Given this list of marker genes VTA1, BCR, SPRTN, SSX5, BCAM, ZFAND4, MTFR1, MPC1, ING5, UFSP1, CBLN4, MRPL41, RAB39B, PTRH2, STYK1, DCK (NCBI Gene Id 1633), C16orf90, ZCCHC17, GART, MAF1, PLPP4, POU5F2, TUBGCP6 (NCBI Gene Id 85378), SLPI (secretory leukocyte peptidase inhibitor), C1orf159, PLEKHN1, USP24, FMR1, SLC16A6, GTF3C6, SMTN, TBC1D9B, DHRS1, D2HGDH, AKNA, VAV1, OR2T33, SRSF1, SLC29A2, LRRC46, ACAP2, DCLRE1B, ATP10A, ZCCHC14, MEMO1, TM9SF3, RNGTT, SETDB1, NADK, P2RX1, NEUROD2, IPPK, PITPNB, HMGXB4 (NCBI Gene Id 96789), INSR, FKRP, ARHGEF1, HYAL3, MSL3, BBOX1, SMIM7, CHD1L, ARSB, USP37, SSX2IP, MTF1, RIF1, ACSL5, MKLN1, MOB3A, CNGA4, PACC1, MAB21L2 (NCBI Gene Id 10586), NOCT, OOEP, KLHL36 (NCBI Gene Id 79786), MIB2, GALC, RUFY1 (NCBI Gene Id 80230), FAM216A, MAS1 (NCBI Gene Id 4142), VIP, RHOG, RAB35, YOD1, PLEKHG3, PAPOLG, SYNDIG1, IFITM10, MOSMO, PCDHB10, KBTBD2, ADHFE1, TMEM181, SCAI, ATP5PB, MDM2 (NCBI Gene Id 84825), GAS7, LRCH4, NAP1L4, CHAF1B, NAT8, POPDC2, DDX17, NRF1, NR2C2, ITGA8, METTL13, HOMEZ, CIMIP1, NDUFA13, RNF157, DPF1, TGM3, DDX55, ADAMTS2, B3GAT3, SHMT1, MDM4, METTL5, FDPS, COL5A1, BCL10, TEKT1, GIN1 (NCBI Gene Id 54826), CCPG1, FUT7, CD81, HCFC1, CSNK1G1, NTNG1, COTL1, NRM, EDARADD (EDAR associated via death domain), FERMT2, OTOP3, ATF5, HMGA2, CSNK1D, IL18BP, BHLHE40, GSK3A, GPR37, GEMIN5, SNX13, EMSY, RAB11B, SCN4B, ATP6V0A1, HNRNPL, ZRANB3, NAT8L (N-acetyltransferase 8 like), ANKRD40, ARMC2, SNRPC, BPIFB2, LYG1, CBLN3, SLC10A3, SLC37A3, SEMA6A, UBAP2 (NCBI Gene Id 57627), BNC2, SEPTIN9, NINJ2, NHERF2, ILKAP, CLEC2L, RBM12, B4GALNT4, TP53BP1, FBXO31, STIM2, PSME3IP1, YJU2, KPNA7, MPHOSPH6, CSDE1, GIPC3, CDC25B, MREG, UHMK1, NFAM1, COL2A1, BCO1, TMEM202, BUD31, ETAA1, CYB561A3, TNKS2, APOC3, RPS6KA3, ITGB2, NOD1, PRR22, CHRNA4, DLL3 (NCBI Gene Id 10683), ZNF142, INTS11, CSN3, here is a description of the gene set: Genes up-regulated in epithelial cells (6h): interferon alpha versus interferon alpha and IFNG. from publication Sanda C, Weitzel P, Tsukahara T, Schaley J, Edenberg HJ, Stephens MA, McClintick JN, Blatt LM, Li L, Brodsky L, Taylor MW (PMID 16800785) Human Gene Set: GSE5542_IFNA_VS_IFNA_AND_IFNG_TREATED_EPITHELIAL_CELLS_6H_UP Type I and type II interferons (IFNs) bind to different cell surface receptors but activate overlapping signal transduction pathways. We examined the effects of a type I IFN (IFN-acon1) and a type II iFN (IFN-g1b) on gene experession in A549 cells and demonstrate that there is a common set of genes modulated by both IFNs as well as a set of gene specifically regulated by each, reflecting the activation of different signaling pathways. In particualr, IFN-g induced many more genes of the signaling pathways, apoptosis, and cytokine interactions than did IFN-a. Even with genes induced by both IFNs there were distinctive quantitativive differences in expression. IFN-g1b plays a major role in the induction and regulation of the complement pathway. Previous work has shown a synergistic antivral and antiproliferative effect of type I and type II IFNs in cell culture and in the treament of tumors in mice. We demonstrate that a majority of genes showed and additive effect of IFN-acon1 and IFN-g1b, but a subset of gene is synergistically induced; these incluce ISG10, MX2, OAS2, and other genes known to be involved in the antiviral response, TRAIL (TNFSF10) and caspases involved in apoptosis and chemokine genes RANTES, CXCL10, and CXCL11. Greater than additive transcription of some of these genes in the presence of both IFNs was confirmed by real-time kinetic RT-PCR. Elevated induction of many of these genes may be sufficient to explain the synergistic antiviral and antitumor effects of this combination of IFNS in vivo. species: Homo sapiens